The following is a description of a gene set: Muscle contraction studied in species Homo sapiens Human Gene Set: REACTOME_MUSCLE_CONTRACTION, and this is the list of marker genes: MYL12A, NKX2-5, CACNG6, ACTA1, CACNG7, KCNE2, ABCC9, SCN10A, GUCY1B1, TMOD4, NPR1, RYR3, MYL6B, VIM, CACNG8, NPPA, ITGA1, HIPK1, KCNIP4, ACTN3, KCNK6, NOS1, TNNT3, PRKACA, MYH6, SCN9A, KCNK4, MYH3, ASPH, KCNJ11, TBX5, MYL5, SCN3A, CACNA1H, MYLK, KCNK18, HIPK2, SCN5A, AHCYL1, KCNE3, FKBP1B, SCN1A, MYL3, DMPK, KCNIP1, MYL12B, TNNI2, KCNA5, CES1, WWTR1, SLC8A3, TNNI3, ATP1A1, TNNT2, KCNJ12, TRPC1, VCL, ORAI1, TMOD3, SCN7A, KCNK3, ATP1B2, KCNK13, ATP1A4, DYSF, ATP1B1, AKAP9, KCNIP3, TNNC2, TPM4, SCN4B, SLC8A1, KCNK2, CACNB2, FXYD1, TPM2, MYBPC1, TNNT1, FXYD7, LMOD1, CAMK2D, KCNK5, KCNK7, SCN8A, RYR1, MYL6, SCN4A, KCND1, ANXA2, ITPR3, SRI, SCN2A, KCNIP2, TCAP, ACTA2, CAV3, MYH11, CAMK2G, CACNA1G, DMD, FXYD6, MYL10, CACNA1I, TTN (titin), SORBS3, PLN, NEB, KCNE5, FGF12, KCNJ2, MYBPC3, ATP2B3, FGF14, GATA4, TNNC1, ATP2A1, MYH8, ACTN2, MME, CAMK2A, SORBS1, RANGRF, CORIN (corin, serine peptidase), KCNJ4, ACTC1, KCNK17, ITPR2 (NCBI Gene Id 3709), CACNA2D2, STIM1, ATP2A2, TPM3 (NCBI Gene Id 91191), SCN3B, SCN11A, ATP2B1, ACTG2, PXN, NPPC, MYL11, SCN2B, ANXA1, CACNB1, PAK2, KCNK9, TMOD1 (tropomodulin 1), ATP1B3, GUCY1A1, KCND3, TMOD2, KCND2, KCNK12 (potassium two pore domain channel subfamily K member 12), CAMK2B, KCNK15, ITGB5, ATP1A3, FGF13, PDE5A, MYL7, MYL9, KAT2B, NPR2, KCNH2, ATP2B2, SCN1B, TPM1, DES, FXYD2, ATP2B4, SLN, CALD1 (NCBI Gene Id 800, caldesmon 1), MYL2, RYR2, MYBPC2, FXYD4, SLC8A2, TRIM72, TLN1, KCNK1, MYL1, CACNA1C, TNNI1, KCNQ1, KCNK16, KCNE4, ALDH2, CACNG4, MYL4, CASQ2, FGF11, TRDN, ATP2A3, ITPR1, CALM1, FXYD3, CASQ1, CLIC2, KCNK10, GUCY1A2, ORAI2, ANXA6, KCNE1, PAK1, ATP1A2, KCNJ14